The following is a description of a gene set: Activated NTRK2 signals through FYN studied in species Homo sapiens Human Gene Set: REACTOME_ACTIVATED_NTRK2_SIGNALS_THROUGH_FYN, and this is the list of marker genes: NTRK2, GRIN2B, BDNF, SRC, FYN, DOCK3, RAC1